Given this list of marker genes IFNG, SOD2, GRIA4, MIR92A1 (microRNA 92a-1), MIR140, RBM10, ESR1, CDKN2A, MAPK7, DIPK2A, IL12B, MAP2K4, MIR210, SLC7A5, DNMT1, MIR138-1, PDE1A, LRP6, PPARG, ATF4, E2F3, SIRT1, MIR1-1, ADCY10, MIR17 (NCBI Gene Id 406952), NR4A3 (nuclear receptor subfamily 4 group A member 3, NCBI Gene Id 8013), LYPD3, MAP2K5, IL12A, EDN1, BAG1, MFN2, APOH, MIR21 (NCBI Gene Id 406991), MIR24-1 (NCBI Gene Id 407012), IGF1 (NCBI Gene Id 3479), FOXO1, STUB1, MIR28, PDCD4 (NCBI Gene Id 27250), here is a description of the gene set: Any apoptotic process in a smooth muscle cell. Smooth muscle consists of non-striated, elongated, spindle-shaped cell found lining the digestive tract, uterus, and blood vessels. Human Gene Set: GOBP_SMOOTH_MUSCLE_CELL_APOPTOTIC_PROCESS studied in species Homo sapiens